Given this list of marker genes Tmem59, Atp7a, Dpy30, Pcsk7, Gper1, Pheta2, Plpp3 (NCBI Gene Id 68448), Golph3l, Tmem87b, Ap1s1 (NCBI Gene Id 11769), Gal3st2, B4galt6, St3gal1, Chid1, Lrrk2, Chst5, A3galt2, Sec1, Sys1, Pld1, Mmp24, Glg1, Azin2, Tmem230, Mme, Pcsk1, Mgat4b, Plekhj1, Csgalnact2, Vrk1, Ap3b1, Slc30a5, Hook2, Bace1, Arfip2, Gpr89, Marchf9, Atxn2, Golga7, Vamp4, Golga5, Nucb1 (NCBI Gene Id 97355), Lrba, Asap2, AU040320, Pacsin3, Sar1a, Trappc6b, Rab27b, Arfgef2, Uso1, Vamp2, Ms4a7, Tgfb2, Phaf1, Slc30a7, Gbf1, Scamp4, Scamp3, Ap4e1, Ggta1, Scamp2, Pick1, Car4, Tjap1, Clip3, Cit, Vps51, Aftph, Pacsin1, Yipf6, Gh, Rab32, Vcpip1, Scamp5, Arfgef1, Clba1, Relch, Pi4k2a, Akap9, Ms4a6c, Marchf4, Furin, Atp8b1, Stx16, Rab30, Clasp2, Cog3, Ap4b1, Lyset, Syt11 (synaptotagmin XI), Slc10a7, Sulf2, Fut4, Vamp5, Bet1, St6gal1, Cby1, Mgat4a, Ap3b2, Bace2, Fam91a1, Ap1s3, Arl1, Lamp2, Pheta1, Lpcat2, Iigp1 (interferon inducible GTPase 1), Arfrp1, Plekha8, Rab11fip3, Bicd1, Atg9b, Atp8a1, B4galt7, Tas2r118, Slc35b2, Tgoln1, Cdh1, Grn, Sgms1, Tmem79, Ntsr2, Ocrl, Nsfl1c, Myo18a, Atp8b3, Arf1, B4galt2, Gcc2, Ap1b1, H2-Q2, Fut2, Bcap31, Lyz2, Fut9, Klhl20, St6gal2, Rab34, Aqp2, Galnt1, Eipr1, Yipf4, Gga1, Slc9a7, Rbfox1, Gosr1, Gsap, Ccdc186, Ndst1 (NCBI Gene Id 74141), Scamp1, Slc35b3, Pam, Zfyve1, Yipf7, Prkd1, Ap4m1, Cpd, Rac1, Rab13, Chst2, Pclo, Atp8b4, Postn, Csgalnact1, Dnaaf6rt, B4galt1, Atl1, Golph3, Gga3, Flna, Fut7, Ap3s1, Mbtps1, Yipf5, Sulf1, Golim4, Acp3, M6pr, Chsy3, Nagpa, Ap3d1, St3gal3, B3galt6, Tepsin, Hspd1, Stx4a, Nucb2 (NCBI Gene Id 53657), Mgat2, Smpd4, Rab21, Tmbim4, Slc66a2, Necab3, Trappc9, Wipi1, Slc11a2, Ap1m1, Rab38, Cln3, H2-K1, Ms4a6d, Becn1, Optn, Cd2ap, Bsn, Rasip1, Lap3, H2-D1, Wdr11, Snx9, Atp2c1, Sorl1, Tpst1, Galnt3, Dnmbp, B4galt3, Syt17, Caln1, Stx6, Sar1b, Abo, Hace1, Nmnat2, Arl5b, St3gal4, Scoc, Slc24a5, Crhr1, Ap1g2 (NCBI Gene Id 11766), Fcmr, Kif13a, Ccdc91, Stx8, Pcsk5, Asap1, Yipf1, Rab14, Lypla2, Golga2, Gpr108, St3gal2, Cog2, B4galt5, Pacsin2, Atp9a, Ap4s1, H2-Q7 (NCBI Gene Id 15018), Vps54, Rab31, Llgl1, Tgfbi, Hid1, Ap1g1, Xylt1, Yipf2, Lyz1, Ap1s2, Myo1b, Vps13b, Cracr2a, 4930568D16Rik, Arap1, Nsf, Nsg1, Ms4a6b, Mgat4d, Tmed3, Fut8, Inpp5e, Chsy1, Plekha3, Trappc4, Rab10, Tmed2, Tmem165, Snap25, H2-Q10, 5730455P16Rik, Atp7b, Bpnt2, Slc30a6, Gal3st3, Sort1, Fut11, Gba1, Rab6a, Rab11a, Chac1, Dnm2, Pik3c2a, Golga1, Dennd5a, Ap3s2 (NCBI Gene Id 11778), Dop1b, Atp9b, Rgs20, Mob4, Atp8b2, Slc39a9, Slc9a8, Bok, Atp2c2, Tmem115, Atp8b5, Birc6, Mlana, Wls (NCBI Gene Id 99763), H2-Q1, H2-Q4, Clvs1, Rab7b, Galnt2, B4galnt4, Tmem87a, Gcnt1, Pcsk1n (NCBI Gene Id 30052), Smpd3, Vps53, Plod3, Adam10, Chst4, Ift88, Scfd1, Baiap3, Cimap3, Golt1a, H2-Q6, Gga2, Arl5c, Bet1l, Rab29, Pi4k2b, Cant1, Slc2a4, Inpp5k, Osbp, Fut1, Prepl, Man2a1, Golga3, Dop1a, Aph1a, Igf2r, Plk3, Uxs1, Lgr5, Atg9a, Nbea, Coro7, Elapor1, Gorasp2, Atp8a2, Pitpnm1, Psenen, Cabp7, Ica1, Tbc1d23, Arl5a, Dnaaf6, Cltb, Trappc6a, B4galnt3, Ece2, Pld4, Tpst2, Arfip1, Clvs2, Nsg2, Ap1m2, Cnst, Gnas, Marchf1, Chpf, Pcsk4, Tom1l1, here is a description of the gene set: A compartment that consists of a lumen and an enclosing membrane, and is part of the Golgi apparatus. species: Mus musculus Mouse Gene Set: GOCC_GOLGI_APPARATUS_SUBCOMPARTMENT